The following is a description of a gene set: Aside from Myc-activating translocations characteristic of plasmacytomas (PCT), little is known about genetic factors and signaling pathways responsible for the development of spontaneous B-cell lineage lymphomas of mice. Here, we characterized the transcriptional profiles of PCT, centroblastic diffuse large B-cell lymphomas (CBL), and high-grade splenic marginal zone B-cell lymphoma (MZL++) using high-throughput quantitative reverse transcription-PCR. Expression profiles of CBL and MZL++ were strikingly similar and quite unlike that of PCT. Among the genes expressed at significantly higher levels by PCT were a number involved in NOTCH signaling, a finding supported by gene set enrichment analyses of microarray data. To investigate the importance of this pathway, NOTCH signaling was blocked in PCT cell lines by treatment with a gamma-secretase inhibitor (GSI) or transduction of a dominant-negative mutant of MAML1. These treatments resulted in reduced expression of NOTCH transcriptional targets in association with impaired proliferation and increased apoptosis. GSI treatment of transformed plasma cells in a primary PCT also induced apoptosis. These results integrate NOTCH activation with oncogenic signaling pathways downstream of translocated Myc in the pathogenesis of mouse PCT, two signaling pathways also implicated in development of human multiple myeloma and T-cell lymphoblastic lymphoma. studied in species Mus musculus Cluster 6 of genes distinguishing among different B lymphocyte neoplasms. Mouse Gene Set: SHIN_B_CELL_LYMPHOMA_CLUSTER_6 from publication Shin DM, Shaffer DJ, Wang H, Roopenian DC, Morse HC 3rd (PMID 19010892), and this is the list of marker genes: Ptgs2, Ifnb1, Wnt1, Id3, S100a8, Six3, Hoxa7, Cdx4, Socs1, Il1b, Lmo2, Hoxa1